The following is a description of a gene set: studied in species Homo sapiens Human Gene Set: REACTOME_MITOTIC_G2_G2_M_PHASES Mitotic G2-G2/M phases, and this is the list of marker genes: HAUS7, TUBB6, CUL1, ALMS1, PSMD3, GTSE1, CEP43, PSMA1, MZT1, RPS27A, HSP90AA1, UBA52, PLK1, PSMA6, PSMA4, PPP2R2A, PPP1R12B, OFD1, CEP135, PSMA5, CETN2, TUBGCP2, CENPF, PPP2R1A, CEP131, PPP2R1B, CEP152, HAUS6, HMMR, PSMA7, PRKAR2B, TUBA4A, FKBPL, PSMB2, PSMC3, PSMB1, SSNA1, FOXM1, PSMB3, AURKA, CSNK1E, PSMD7, TUBA1A, TUBGCP6, BORA, DCTN1, E2F3, CDC25C, PSMD11, ADRM1, CCNA2 (cyclin A2), PKMYT1, MAPRE1, PSMA3, TUBAL3, CCNA1, CDK5RAP2, AKAP9, TUBB8B, AJUBA, PPP1CB, CDC25A, WEE1, DYNC1I2, TUBB3, DYNC1H1, TUBA1B, TPX2, FBXL7, HSP90AB1 (heat shock protein 90 alpha family class B member 1), PLK4, CCNB2, HAUS3, FZR1, TUBA8, SKP1, HAUS1, LIN54, TUBA3E, CDK1, TP53, PRKACA, PSMC1, PAFAH1B1, TUBA4B, PSMA2, PSMD2, TUBG2, CCNH, TICRR, PHLDA1, SGO1, TUBB1, CEP76, FBXW11 (NCBI Gene Id 23291), TUBG1, CEP290, E2F1, RAB8A, MIS18BP1, ACTR1A, SEM1, PSMD14, TUBB4B, CDK2, DCTN2, PPP2CA, MYBL2, CDKN1A, CEP192, TUBGCP3, TUBA3D, CDC25B, CDK11B, PSMD1, XPO1, TUBB2A, DCTN3, PPP2R3B, HAUS8, PSMD12, CSNK1D, PSMC4, CEP57, CNTRL, CENPJ, BTRC, PSMB6, PSMD8, CEP164, SDCCAG8, CCNB1, UBB, RBX1, RBBP4, HAUS2, HAUS4, YWHAG, NME7, TUBB2B, CCP110, PSMB5, TUBGCP5, NEDD1, CDK7, CDK11A, MZT2A, PSMB7, TUBA1C (tubulin alpha 1c), UBC, SFI1, LIN52, OBI1 (NCBI Gene Id 86572), ODF2 (NCBI Gene Id 4957), DYNLL1, HJURP (Holliday junction recognition protein), PSMC6, CEP72, PSMC5, CEP70, CEP78, NEK2, MNAT1, PSMD6, NINL, MZT2B, FBXL18, LCMT1, TUBGCP4, PPP1R12A, OPTN, PSMB4, CEP63, TUBB4A, TUBB, TUBA3C (tubulin alpha 3c), PPME1, PSMD13, CEP250, TUBB8, CEP41, EP300, CLASP1, LIN37, NDE1, PSMC2, LIN9, YWHAE, PPP2CB, PCM1, HAUS5, PCNT, CKAP5 (NCBI Gene Id 9793)